Given this list of marker genes RRBP1, ATP1A1, EIF1 (eukaryotic translation initiation factor 1), NCL, STAT3, EIF4G2, RPSA (NCBI Gene Id 3921), YBX3, CPD (carboxypeptidase D), CLDN10-AS1, ADAMTS1, DEPTOR, ARF1, RPS15, IQGAP1, WFDC2, FCHO2, HINT1, HSP90B1, ZMYND8, CCT3, RPL24, TFPI, PSAP, RPS8, MYL12A, HNRNPR, PSMB1, RPLP2, RPL19, OSMR, RPS16, RPS29, YWHAB, NARS1, RPLP0 (ribosomal protein lateral stalk subunit P0), PTGES3, APP, RPS6, SLC25A3, TSC22D1 (TSC22 domain family member 1), BTG1, SRSF3, CIB1, NUFIP2, XRCC5, EEF1D, SOD2, ARPC1B, JAK1, UBC, PDIA3, GNAS, LDHA, SNX10, CD59, TCIM, COX5B, PLSCR1, RPS27A, CTNNA1, CD164, SLPI, TPI1, GHITM, ZFAND5, PSMA7 (proteasome 20S subunit alpha 7), CDH16, PDIA6, ARFGAP3, MTUS1, RPS13, TMEM59, BTF3 (basic transcription factor 3), RPL8, JTB, S100A11, RPS19, APLP2, NCOA7, SOD1, CTSB, TNFSF10, PRKD1, RPS7, CD24, GOLM1 (golgi membrane protein 1), TACSTD2, RIMS2, STK24, RPL12, RPL32, RPS11, SERF2, UBE2D3, TNS3, HNRNPU, SEPTIN7, EFNA5, ATP5F1C (ATP synthase F1 subunit gamma), RPL41, NORAD, TGM2, FTL, LAMTOR5, HIF1A, SDCBP, SELENOW, LITAF, VMP1, SRP14, PTPN11, ACSL4, CRYAB, CD46, NEK10, GADD45B, EMP1, HLA-A, CD81, EIF5, RPS5, COX4I1, RPL31, RASD1, PRDX1, ITGB6, MYL6, HNRNPDL, UBA52, TPST1, RPS14, GNAI1, CDC42BPA, KRT7, MAOA, MCL1, HSP90AB1, EPCAM, FAM135A, RPS9, SARAF, RPL15, ALDOA, DSTN, RPL10, PPP2R3A, ERRFI1, RPL10A, RACK1, HADHB, CD63, RALGAPA2, ATP6V0B, RPS4X, ENO1, PNPLA8, FTH1, LRRFIP1, SERPING1, IDH2, CYSTM1, TAX1BP1 (Tax1 binding protein 1), DDX5, TOP2B, HLA-E, ANKRD10, UBXN4, EPRS1, RPS3A, PTMA, RARRES2, YBX1, HSP90AA1, PPIA, COX7C, RPS12, ITM2B, SLC4A7, CSDE1, RPL18, SLC38A2, RPS28, IFITM2, CALM1, RPL14, ATP5F1B, PANTR1, HSPD1, RPL5, CLINT1, DEK, LRP10, TM9SF3 (transmembrane 9 superfamily member 3), HLA-B, RHOA, CCDC186, B2M, KRT18, CAPN2, PON2, ITM2C, RPL9, ID2, BCL6, IFITM3, RPS17, MRFAP1, PRDM16-DT, G0S2, RPS20, RPS25, HSBP1, BACE2, RAN, S100A10, KIF5B, EEF1A1, PCBP1 (NCBI Gene Id 5093), ACTR2, REEP5, SLC16A7, ITGB1, RPL6, MYL12B, CNDP2, NRXN3, SLC25A5, GAPDH, LAPTM4B, RPL3, LINC01503, UBB, SF3B1, RPL35, SERPINA1, EID1, KNG1 (kininogen 1), CEBPD, PLPP3, RPS27, PRDX6, PKM (NCBI Gene Id 8127), TXNIP, PFKFB3, ATP5MC3, CD44, RPL13, IER3, CCT6A, CNN3, CYCS, LDHB, ADGRG1, C6orf62, ITGA2, NAMPT, H3-3B, RPL7, PTTG1IP, DBI, NPM1, HNRNPA3, DNAJA1, PFDN5, PEBP1, ZC3H11A, MTCH1, CD74, ATP5F1A, ACTG1, CPM, GSTP1, SPPL2A, TPT1, PGK1, ZFP36L2, MKLN1, CLDN10, ZC3H15, HADHA, ELF3, RPS24, SAT1, HIPK3, RPL11, GPX1, PLEKHA1, OCIAD1, RPLP1, VPS13C, HSPA9, UQCRFS1 (ubiquinol-cytochrome c reductase, Rieske iron-sulfur polypeptide 1), RPL13A, UMOD, PITPNC1, EIF4A2, DIAPH1, TIMP1, GSPT1, FAU, PLOD2, IVNS1ABP, PNRC1, SASH1, CACNA2D3, RPL37A, OSBPL3, SKAP2, ATP6V0E1, RPL21, LINC01320, RPS2, HSPA8, ACADVL, RPS18, ADAM10, PABPC1, DUSP23, SERBP1, MT2A, DNAH5, S100A6, SEC14L1, CANX, SPP1, RPL4, TMF1, GDF15 (NCBI Gene Id 9518), NDUFA4, FNIP2, HNRNPM, SIM2, ANXA5 (NCBI Gene Id 308), CNBP, EEF2, RPL7A, PAPOLA, HSPH1 (NCBI Gene Id 9835), TMBIM6, TAF7, ANXA2, GCC2, MGLL, HNRNPA2B1, CBR1, ITPR2, RPS23, RPL30, CXXC5, UQCRB, ATP5F1E, PPA1, here is a description of the gene set: Human Gene Set: LAKE_ADULT_KIDNEY_C10_THIN_ASCENDING_LIMB from publication Lake BB, Chen S, Hoshi M, Plongthongkum N, Salamon D, Knoten A, Vijayan A, Venkatesh R, Kim EH, Gao D, Gaut J, Zhang K, Jain S (PMID 31249312) studied in species Homo sapiens